Given this list of marker genes Apoe, Cdh8, Adgrb3, Cbln3, Cbln4, Dnm3, Gria3, Grin1, Slc1a1, Egflam (EGF-like, fibronectin type III and laminin G domains), Cbln2, Nptx1, Grip1, Nptx2, Grin2b, Nxph1, 2510002D24Rik, Prss12, Lama2, Lamc1, Lamb2 (laminin, beta 2), C1ql1, Cbln1 (NCBI Gene Id 12404), Nlgn1, Lama5, C1ql2, Ache, Lama4, Lgi1, Lrit1, C1ql3, here is a description of the gene set: studied in species Mus musculus The narrow gap that separates the presynaptic and postsynaptic membranes, into which neurotransmitter is released. Mouse Gene Set: GOCC_SYNAPTIC_CLEFT